The following is a description of a gene set: Human Gene Set: MIR887_5P from publication Chen Y, Wang X (PMID 31504780) Genes predicted to be targets of miRBase v22 microRNA hsa-miR-887-5p in miRDB v6.0 with MirTarget v4 prediction scores > 80 (high confidence targets). studied in species Homo sapiens, and this is the list of marker genes: PRSS27, KLHL4 (NCBI Gene Id 56062), TENM4, MLLT6, CARHSP1 (calcium regulated heat stable protein 1), PTPN21, CDC42BPA, TSPAN12, EBAG9, MAML1, SKIDA1, TNRC6A (NCBI Gene Id 92763), ATP1B4, MAPK10, KLHL5, TTLL10, ARHGAP9, ZNF569, C2CD6, MAGEB2, CHP1 (NCBI Gene Id 11261), GPBP1L1, CORO1C, MKX, ILF3, PLEKHA5, CDADC1, NFIC, TUBB, SYP, WASF2, EEF2K, PPDPFL, APOBEC3F, GPATCH2, MKKS, DDX6, MXRA5, RPS6KA5, ATG16L2, SPHKAP, MYO5A, BAZ2A, SYT14, ZNF275, MTCL2, KCNH5, SPI1, GAGE1 (G antigen 1), FER, SUCLA2 (NCBI Gene Id 8803), PDF, HOOK3, STX5, SNAPC3, HNRNPL, MBNL3, LURAP1L, RAB37 (RAB37, member RAS oncogene family), SLC66A1LP, IGDCC3, FAM117A, COG8, IKZF3, ASPH, IFI27L1, METTL8, GPR158, GPC6, CDK8, TECRL, SMDT1 (NCBI Gene Id 91689), YWHAQ, CCDC28A-AS1, ADAM30, SPATA6, SLC36A1, STAT6, DUSP19, KRT222, C1orf105, HS6ST2, CLIC5, GUCY1A2, PLEKHS1, MIP, BTD, NAT1, FRMD4A, GAGE12D, MTCH2, UBQLN1, CREM, SRRM4, CBX5, SLC16A1, TAOK1, LUZP1, ISL2, MPPED2, PTBP3, KIAA1549 (KIAA1549), ANKRD17, RNFT2, VSNL1, TRIM32, ARID4A (AT-rich interaction domain 4A)